Given this list of marker genes AKR1C1, AKR1C2, CYP8B1, SLC27A5, CYP39A1, AKR1D1, SLC27A2, HSD3B7, CYP27A1, AKR1C3, AKR1C4, CYP46A1, AMACR, here is a description of the gene set: In the body, 24-hydroxycholesterol is synthesized in the brain, exported to the liver, and converted there to bile acids and bile salts. This pathway is only a minor source of bile acids and bile salts, but appears to be critical for the disposal of excess cholesterol from the brain.<p>In the liver, conversion of 24-hydroxycholesterol to bile acids and bile salts is initiated with hydroxylation and oxidoreductase reactions to form 4-cholesten-7alpha,24(S)-diol-3-one. The pathway then branches: hydroxylation of 4-cholesten-7alpha,24(S)-diol-3-one to 4-cholesten-7alpha,12alpha,24(S)-triol-3-one leads ultimately to the formation of cholate, while its reduction to 5beta-cholestan-7alpha,24(S)-diol-3-one leads to chenodeoxycholate formation. In both branches, reactions in the cytosol, the mitochondrial matrix, and the peroxisomal matrix result in modifications to the ring structure, shortening and oxidation of the side chain, conversion to a Coenzyme A derivative, and conjugation with the amino acids glycine or taurine. These reactions are outlined in the figure below. The final three reactions are identical to ones of bile salt synthesis initiated by 7alpha-hydroxylation and are shown as arrows with no substrates. part of: Synthesis of bile acids and bile salts studied in species Homo sapiens Reactome Pathway: Synthesis of bile acids and bile salts via 24-hydroxycholesterol